The following is a description of a gene set: studied in species Homo sapiens Human Gene Set: GOBP_NUCLEAR_RECEPTOR_MEDIATED_SIGNALING_PATHWAY The series of molecular signals initiated by a signaling molecule binding to an intracellular receptor of the nuclear receptor protein family, and ending with regulation of a downstream cellular process, e.g. transcription., and this is the list of marker genes: GHRHR, PPARGC1B, TGIF1 (TGFB induced factor homeobox 1), PLA2G10 (NCBI Gene Id 8399), TRIM68, STUB1, NR1H2, LEP, DAB2, PTF1A, SFRP1, DDX5, RARA, PLPP1, HDAC6, PIM1, ISL1, CLOCK, DNAAF4, USP26, GPER1, GPS2, ALOX15B, PML, SP100, DDRGK1, ZNF536, RWDD1, NR1H4, LBH (NCBI Gene Id 81606), SCGB2A2, PRCP, NCOR1, NR0B1, STRN3, TRIP4, CNOT2, MN1, KDM4C, PMEPA1, EP300, CRKL, FOXP1, PDK3, TRIM24, PARP1 (NCBI Gene Id 142), WBP2, GPHB5, TBX1, TRIM16, NCOA4, POU4F2, BMP2, NCOA1, DEFA3, ZMIZ1, ALOX15, SNW1, PHB2, LATS1, CNOT1, PAK1, UBR5, ESRRA, CARM1, ESRRB, DHRS3, PTGIS, THRA, FOXA1, RARG, JAK2, NR4A3, PAQR8, AKR1C3, ABHD2, KLF2, ACTN4, TMF1, SAFB, DEFA1B, NCOA3, FAM120B, PKN1, PPARA, RXRB, NR2E1, PAGR1, PRAME, ASXL2, GPRIN3, UFSP2, ALDH1A2, ZDHHC7, BMAL1, PHB1, RXRA, NCOR2, UBE3A, ASXL1, TAF7, NODAL, DDX54, TWIST1, KDM3A, MIR27B, TADA3, HDAC2, KDM1A, ZBTB7A, DEFA1, PGR, RXRG, DDX17, RHOA, DAXX, PER1, CDK12 (cyclin dependent kinase 12), MED1, IGF1, RBFOX2, CYP24A1, CYP7B1, CYP26A1, HUWE1, SRARP, TCF7L2, HEYL, PAQR3, YWHAH, PARK7, CTBP2, UFM1, CRY2, VPS18, HMGA2, ESRRG, MIR34A, NR2E3, EZH2, VDR, PAQR7, RNF14, CALR, FKBP4, KDM5D, LMO3, PPP5C, PIAS2, MIR613, AR, MIR208A, SRC, RARB, SIRT1, GREB1L, PDE3A, PLIN5, SCGB2A1, FSHR, EGLN2, ESR2, THRB, NKX3-1, ALOXE3, CREBRF, PPARG, CRY1, TAF1, UBA5, ZNF366, CST11, NR1D1, NR2C1, ESR1, PPARD, OR51E2, SAFB2, CYP26C1, NR3C1, FABP5, CALCOCO1, CYP26B1, NR3C2, JUND, UFL1, PADI2, SHQ1, NEDD4, KANK2, TP63, PGRMC2, NCOA2, CCDC62 (NCBI Gene Id 84660), PRMT2, CITED2, RHOXF1, SNAI2, FOXH1, RNF6, SKP2, KMT2D, VPS11, TCF21, BRCA1, CNOT9, CYP27B1, SMARCA4, HDAC1, ERRFI1, TRERF1